Given this list of marker genes Ubc, Dtx4, Notch1, Itch, Uba52, Ubb, Jag2, Uba52rt, Rps27a, Dtx2, Dtx1, here is a description of the gene set: Mouse Gene Set: REACTOME_ACTIVATED_NOTCH1_TRANSMITS_SIGNAL_TO_THE_NUCLEUS Activated NOTCH1 Transmits Signal to the Nucleus species: Mus musculus